The following is a description of a gene set: Mouse Gene Set: REACTOME_NEGATIVE_REGULATORS_OF_DDX58_IFIH1_SIGNALING Negative regulators of DDX58/IFIH1 signaling species: Mus musculus, and this is the list of marker genes: Ikbke, Pin1, Rigi, Irf3, Tax1bp1, Ubc, Rps27a, Tbk1, Ubb, Cyld, Uba52rt, Nlrx1, Uba52, Tnfaip3, Mavs